The following is a description of a gene set: Human infertility and recurrent pregnancy loss caused by implantation defects are poorly understood. Hoxa-10-deficient female mice have severe infertility and recurrent pregnancy loss due to defective uterine implantation. Gene expression profiling experiments reveal that Hoxa-10 is an important regulator of two critical events in implantation: stromal cell proliferation and local immunosuppression. At the time of implantation, Hoxa-10 mediates the progesterone-stimulated proliferation of uterine stromal cells. Hoxa-10 mutants express a stromal cell proliferation defect that is accompanied by quantitative or spatial alterations in the expression of two cyclin-dependent kinase inhibitor genes, p57 and p15. Hoxa-10 deficiency also leads to a severe local immunological disturbance, characterized by a polyclonal proliferation of T cells, that occurs in place of the normal progesterone-mediated immunosuppression in the periimplantation uterus. Mouse Gene Set: YAO_TEMPORAL_RESPONSE_TO_PROGESTERONE_CLUSTER_10 from publication Yao MW, Lim H, Schust DJ, Choe SE, Farago A, Ding Y, Michaud S, Church GM, Maas RL (PMID 12554760) Genes co-regulated in uterus during a time course response to progesterone: SOM cluster 10. studied in species Mus musculus, and this is the list of marker genes: Psma4, Apmap, Hspe1 (NCBI Gene Id 15528), Fkbp2, Rln1, Grwd1, Serp1, Slc30a5, Canx, Ap4s1, Pcna, Dynll1, Ssb, Mpc2, Bola2, Trir, Rangap1, Uso1, Cdk2ap2, Sarnp, Ssu72, Rrbp1, Edf1, Arcn1, Ldha, Cldn7, Cct7, Prdx1, Dad1, Sec61a1, Tm9sf3, Ssrp1, Ostc, Cers2, Mfsd14a, Bckdhb, Sumo1, Cox17 (NCBI Gene Id 12856), Fkbp4, Eif3g, Tmed2 (NCBI Gene Id 76322), Mrpl53, Timm23, Polr2f, Ufm1, Cacybp, Atf1, Hnrnpr, Rpn2, Hnrnpa3, Pex2, Yipf5, Vdac2, Sf3a3, Mrpl40, Slc1a4, Gsdme, Chchd7, Eif1b, Hba-ps3, Polr2l, Gcsh, Hbb-bs, Tmem11, Rala, Ap3m1, Qng1, Nsun2, Tceal9, Adk, Pex13